Given this list of marker genes GLDN, SCLT1, SPTBN4, AGRN, NRCAM, MYOC (NCBI Gene Id 4653), here is a description of the gene set: species: Homo sapiens The process in which voltage-gated sodium channels become localized together in high densities. In animals, nodes of Ranvier differ dramatically from internodal axonal regions in very high densities of voltage-dependent sodium (Nav) channels responsible for the rapid, inward ionic currents that produce membrane depolarization. Human Gene Set: GOBP_CLUSTERING_OF_VOLTAGE_GATED_SODIUM_CHANNELS